The following is a description of a gene set: The functional relationships and properties of different sub-types of dendritic cells (DC) remain largely undefined. We used a global gene profiling approach to determine gene expression patterns among murine splenic CD11c high DC subsets in an effort to better characterise these cells. Human Gene Set: GSE339_CD4POS_VS_CD8POS_DC_IN_CULTURE_UP species: Homo sapiens from publication Edwards AD, Chaussabel D, Tomlinson S, Schulz O, Sher A, Reis e Sousa C (PMID 12816982) Genes up-regulated in comparison of CD4 dendritic cells (DC) versus CD8 DCs., and this is the list of marker genes: CETN1, RBBP4, VAPA, KAT7, PLXND1 (plexin D1), LONP1 (lon peptidase 1, mitochondrial), DRAM2, H1-3, IL12RB2, S100A6, TCF7, RTN3, FGF5, NRG3, CHRNA1, ANKH, FKBP3, DDX5, RYR3, MAN1A1, MTX2, PLEKHA1, ICAM2, MED11, CR1L, APOA5, KRTAP19-5, MAP3K1, SLC22A17, FADD, RGS2, RPP30, HOXA4, STAT4, RMC1, ABCC9, RAC1, SNRPG, TIMM8A, PRKACB, NDUFAF4, AQP8, BCL10, S100A4 (S100 calcium binding protein A4), KLHL7, CRYBG1, SIAH2, ABHD8, MS4A6A, NECTIN3, GGH, PLA2G4A, MDFIC, NUS1, CFP, HSP90AA1, ZKSCAN1, GBE1, NDUFA12, SEMA4D, TCF21, NAE1, HSPA9, MYADM, KPNB1, CSK (NCBI Gene Id 1445), PRKCB, MSH6, CHRM4, TCEAL9, RORA, KLRD1, RAB4A, NSMCE3, PSMD8, FBXO45, FN1, MEOX1, TPGS1, SERINC1, ZNF841, RHOB, TPP2, PNPO, MVD (mevalonate diphosphate decarboxylase), IRS2, CDKN2B, ST8SIA1, LAMP2, CPSF7, POLR2G, MATR3, TPD52 (NCBI Gene Id 7163), LTB, UBL5, PTPRB, FRAT1, DMP1, FABP5 (fatty acid binding protein 5), MOGAT2, EIF3E, WDR26, DDHD1, FAM107B, TNFSF4, SLC2A8, HSPH1, CTSV, ABCB1, KLF4, TRIM21, CNOT6L, PAXBP1, RGCC, PLK2, MIS18BP1, SLC2A3, UBAP2L, ACVR2A, UBE2N, HNRNPLL, SH3BGRL, PRF1, GNB1, STAM, TNFRSF11A, THUMPD1, MMP12, SP3, HNRNPDL, B4GALNT1, PDE6D, SARNP, PRM3, RHOQ, ACTN2, CBX3, H1-0, RNF2, NUDC, CTSZ, DTX1, DHRS3, PPP6C, MYO10, ZRSR2, RPL23, LTA4H, NUFIP1, CSTF1, HNRNPUL2, HCCS, ALDH1A3, SLC12A4, GTF3C4, NUDT19, EPHA3, CCR6, MAP3K3, DGAT1, TYROBP, DDR1, IFI27L2, ANKRD28, SF3B1, TUBA3C, WDR75, ARHGAP9, GNAO1, ZNF638, RNF13, XIST (NCBI Gene Id 7503), PIP4K2A, IFIT3, MAP7D1, ARF3, EGF, ADRA2B, RAD23B, KRAS, MDH2, CLK2, ATG5, RB1, CMIP, RAP1A, UBE2D3 (NCBI Gene Id 7323), CHTOP, CLK1, BMPR1B, ARGLU1, ZBTB2, EML5, CHORDC1, THAP12, IFIT2 (NCBI Gene Id 8375), AZIN1, HMGB4, PSMA6, HIF1A